The following is a description of a gene set: species: Homo sapiens The process that results in the uptake of a G protein-coupled receptor into an endocytic vesicle. Human Gene Set: GOBP_G_PROTEIN_COUPLED_RECEPTOR_INTERNALIZATION, and this is the list of marker genes: CALCA, DRD2, ARRB1, APELA, APP, GTF2H2, NECAB2, ARRB2, UBQLN2, APLNR, SAG, ADM, DRD3, APLN, ARR3, PLD2 (NCBI Gene Id 5338)